Given this list of marker genes NPFF, LIPF, AFF4, TNK1, DAO, PCDHGC3, PALLD, ARMC6, KCNE1, TTI2, MSR1, ONECUT2, GGCX, KCND2, SS18, SARS2, HSD17B2, UBC, TRO, CCL11, MARK1, CLEC3B, PCDHA6, APOBEC2 (NCBI Gene Id 10930), POPDC2, PKD1P6, LCP2, ZMYM6, SPATA7, CARD14, NRAP, IGFBP5, B3GAT3, RTCB, ATAT1, DPYS, ADGRL1, IMPDH2, CLDN9, CDK4, SYMPK, HDDC2, ERBB2 (NCBI Gene Id 2064), RING1, ACE, GSTM2, ADAMTS2, OR10C1, TENM1, GPD2, GYPC, DDX6, MTARC1, ADRB1, ACTR5, HSD3B1, FAM215A, CABP1, DAPK3 (death associated protein kinase 3), SHOX2, HOXD12, BCAM, WSCD1, ZNF16 (NCBI Gene Id 7564), CTSG, OR1D2, CDK5R1, ARC, CEP112, MMP1, DHRS1, DHX38, SLC27A2 (solute carrier family 27 member 2), PPAN, COL1A2, ZFPL1, HSD3B2, SLURP1, ACD, FOXB1, SLC2A4RG, MALL (mal, T cell differentiation protein like), HCRT, MTA2, LINC01565, FBXW11, FBXO24, INTS14, TSPAN6, PRDM16, PES1, SLC13A4, SYNGR3, PCDH12, ACTG1, PTGDR, AKR7A3, YKT6, SLC22A8, DCLRE1B, DRD3, HMOX1, PDGFRB, KCNH4 (NCBI Gene Id 23415), CRISP2, COMMD3, FN3K, SZT2, MRPL34, CHRM2, IGKV4-1, RAB27B, CSN3, AIFM1, MYCNOS, SLC28A2 (NCBI Gene Id 9153), RAB6B, RNASE3, COQ6, CCDC88C, ASB8, C10orf95-AS1, VANGL1, MUC1, P2RY11, ANXA2P1, CRACDL, MTHFR, COL11A2, VPREB3, TPSAB1, KRT76, CYP26A1, KCNS1, RND2, ITGB8 (integrin subunit beta 8), FAM131B, FEN1, RASL10A, ADGRF1, LRRFIP2, TM6SF2, RRAGC, KHDRBS2, IMPACT, PPEF1, SH3TC1, CPVL, FOXO1, CLN6, PRRX2 (NCBI Gene Id 51450), CHM, C3orf18, IL1RL2, GSDMD, CALML5, HTR7P1, MFAP4, BTN2A3P, ADAM20, SYDE1, ZFP36, ZMIZ2, RAG2, GJA3, KPNA6, TCEA2, INCENP, KHDRBS3, CPN1, TMEM214, IL17B, TCF21, CYTL1, HTR4, ESR1, CTSA (cathepsin A), OGFOD3, BHLHE41 (basic helix-loop-helix family member e41), SULT1A2, NDOR1, PACS2, SHH, CACNG2, HCAR3, COQ8B, PYY2, OR2B6, ADD1, KCNN3, GCNT1, GOLGA2P5, POU6F2, NOX1, GNRH1 (gonadotropin releasing hormone 1), SERPINI2, JRK, here is a description of the gene set: from publication Lund R, Aittokallio T, Nevalainen O, Lahesmaa R (PMID 14607935) Genes up-regulated in CD4 T cells activated by anti-CD3 and anti-CD28: IL-12 (6h) versus TGFB1 and IL-12 (6h). Human Gene Set: GSE2770_IL12_VS_TGFB_AND_IL12_TREATED_ACT_CD4_TCELL_6H_UP Th1 and Th2 cells arise from a common precursor cell in response to triggering through the TCR and cytokine receptors for IL-12 or IL-4. This leads to activation of complex signaling pathways, which are not known in detail. Disturbances in the balance between type 1 and type 2 responses can lead to certain immune-mediated diseases. Thus, it is important to understand how Th1 and Th2 cells are generated. To clarify the mechanisms as to how IL-12 and IL-4 induce Th1 and Th2 differentiation and how TGF-beta can inhibit this process, we have used oligonucleotide arrays to examine the early polarization of Th1 and Th2 cells in the presence and absence of TGF-beta after 0, 2, 6 and 48 hours of polarization. species: Homo sapiens